The following is a description of a gene set: studied in species Homo sapiens Epilepsia partialis continua Human Gene Set: HP_EPILEPSIA_PARTIALIS_CONTINUA Epilepsia partialis continua (also called Kojevnikov's or Kozhevnikov's epilepsia) is a type of focal motor status epilepticus characterized by repeated stereotyped simple motor manifestations such as jerks, typically of a limb or the face, recurring every few seconds or minutes for extended periods (days or years)., and this is the list of marker genes: GABRG2, SCN1B, SCN9A, POLG, MRM2, TEFM, TWNK, PCDH19, SCN1A, GABRA1 (gamma-aminobutyric acid type A receptor subunit alpha1), COQ8A, SCN2A